Given this list of marker genes MIR21, ATCAY, ATP2B4 (NCBI Gene Id 54594), SLC7A11, SIRT4, CLN3, NR1H4 (nuclear receptor subfamily 1 group H member 4), here is a description of the gene set: Any process that modulates the frequency, rate or extent of the chemical reactions and pathways involving amino acids of the glutamine family, comprising arginine, glutamate, glutamine and proline. Human Gene Set: GOBP_REGULATION_OF_GLUTAMINE_FAMILY_AMINO_ACID_METABOLIC_PROCESS studied in species Homo sapiens